The following is a description of a gene set: Human Gene Set: GAVISH_3CA_METAPROGRAM_B_CELLS_PROGENITOR In this study, an extensive analysis was conducted to define meta-programs (MPs) capturing intra-tumor heterogeneity across a spectrum of tumor types. The approach utilized non-negative matrix factorization (NMF) to analyze each cell type separately within individual tumor samples. This involved the analysis of malignant cells, macrophages, fibroblasts, endothelial cells, epithelial cells, T-cells, and B-cells. NMF was executed with varying parameter values (K=4, 5, 6, 7, 8, 9), thereby generating 39 programs for each cell type per sample. Each NMF program was summarized by the top genes based on NMF coefficients.\nRobust MPs were then delineated for each cell type using a set of stringent criteria, including recurrence within the same tumor, similarity to programs in other tumors, and non-redundancy within a tumor. Subsequently, these robust NMF programs were clustered (per cell type) based on Jaccard similarity, leading to the identification of MPs associated with each cell type.\nTo enhance the quality of the MPs, a refinement steps were undertaken, involving the removal of MPs suspected of reflecting low-quality data (with an overrepresentation of ribosomal proteins or mitochondrial-encoded genes), single-study inclusion, or similarity to miss-annotated cell types. Genes upregulated in subsets of cells of a given type within various tumors from publication Gavish A, Tyler M, Greenwald AC, Hoefflin R, Simkin D, Tschernichovsky R, Galili Darnell N, Somech E, Barbolin C, Antman T, Kovarsky D, Barrett T, Gonzalez Castro LN, Halder D, Chanoch-Myers R, Laffy J, Mints M, Wider A, Tal R, Spitzer A, Hara T, Raitses-Gurevich M, Stossel C, Golan T, Tirosh A, Suvà ML, Puram SV, Tirosh I (PMID 37258682) studied in species Homo sapiens, and this is the list of marker genes: STMN1, H1-10, VPREB1 (NCBI Gene Id 7441), ITM2C, YBX3, PCDH9, IGLL5, CCDC191, MLXIP, CCDC112, DNTT, RCSD1, CD99, PTPRE, CD72, TP53INP1, BACH2, NEIL1, GAPDH, TCF4, TCL1A, VDAC1, LDLRAD4, SOX4, NIBAN3, GLRX, TRAM1, CD9, UBE2J1, VPREB3, NSMCE1, BCL7A, CD24, ARPP21 (NCBI Gene Id 51183), CDC25B, CMTM7, HMGB2, S1PR4, TKT, CD38, IGLL1, SNHG7, MZB1, EBF1, MME, RGS2, TMEM243, TOP2B, SSBP2, MT1X